Given this list of marker genes ANO6, TLR4, IL17RA (NCBI Gene Id 23765), IL17A, IL17RC, here is a description of the gene set: COVID-19 and endothelial cell senescence Human Gene Set: WP_COVID19_AND_ENDOTHELIAL_CELL_SENESCENCE studied in species Homo sapiens